The following is a description of a gene set: species: Mus musculus Mouse Gene Set: GOBP_RNA_EXPORT_FROM_NUCLEUS The directed movement of RNA from the nucleus to the cytoplasm., and this is the list of marker genes: Alyref, Nrde2, Ddx25, Ddx39a, Cpsf6, Nup214, Sarnp, Nup62cl, Fyttd1, Alyref2, Nxf7, Nup153, Gle1, Xpo1, Nsun2, Alyreffm11, Nxt1, Ncbp2, Iws1, Casc3, Khdrbs1, Nup133, Ddx39b (DEAD box helicase 39b), Thoc5, Thoc2l, Alyreffm14, Pcid2, Nol6, Magohb (NCBI Gene Id 66441), Thoc7, Thoc6, Xpot (NCBI Gene Id 97647), Rbm15b, Nup62, Poldip3, Ssb, Ncbp1 (NCBI Gene Id 60346), Ncbp3, Fmr1, Alkbh5, Alyreffm9, Setd2, Alyreffm1, Nup107, Alyreffm3, 1700017N19Rik, Sem1, Eif4e, Thoc2, Pom121, Hhex, Nup93, Alyreffm8, Pom121l2, Nup85, Pabpn1, Ddx19b, Magoh, Nxf1, Alyreffm2 (NCBI Gene Id 639032), Nxt2, Wnk1, Ythdc1, Thoc3, Alyreffm6, Rae1, Nxf3, Nup188, Nup98, Rbm8a, Nup88, Phax, Eny2, Nxf2, Xpo5, Dhx9, Tpr, Nup155, Srsf3, Akap8l, Alyreffm10, Thoc1, Rbm33, Zc3h11a, Hnrnpa2b1, Ddx19a, Alyreffm7, Alyreffm5, Alyreffm4, Supt6, Eif4a3, Chtop, Nup160, Mcm3ap